Given this list of marker genes SLC25A28, WDR75, ATP10D, BEND5, TMA7, TBXT, N6AMT1, PLA2G12B, NCF2, ACTN1, DYDC2, SEZ6L2, DPF3, MRPS31, MAP1A, SLURP1, CYP2E1, NLRP12, SEMA6C, TTN (NCBI Gene Id 7847), GRB2, PPDPF, CDH10, FKTN, EGF, R3HDM2, PRKAG3, BSN, FPR2, AQP2 (NCBI Gene Id 359), IBSP, SYNPO2L, TXNDC5 (NCBI Gene Id 81567), SAGE1, PCDHGB6, ZNF462, TMEM45A, STX1B, RBM23, SPRTN (NCBI Gene Id 83932), NECTIN2, SYT4, WNT4, CNBD2, MYH14, LILRA1, PERP, CLDN14, CAPNS2, SLCO1A2, SCAPER, PGLYRP4, RGS16, NDUFA2, POF1B, GALNT15, TRAPPC6A, BLOC1S6, SUSD4, BCAS4, INPP1, REM2, DHRS3, PLXNA1, DRC7, BAAT, P2RX7, RASL12, PGS1, SNX10, KLRG1, SPP2, CDKN2B, MAPK9, IL1A, EIF3H, CRYGA, PER1, KLK11, TLX1, FETUB, XKR4, ZDBF2, HIC2, ZNF214, GTF3C4, SEMG1, DNAJC10, DMWD, TBC1D8B, UBE2C, KIAA0319, RAB27A, CDO1, NOX4, GPC4, EPS8L3, STAR, NDC80, MYO3A, TSPAN8, DNAJC28, TGM7, PABPC3, OR51E2, DSG1, HOOK1, DGKI, EIF4EBP1, WNT10B, PTPRR, TMEM200A, MUCL1 (mucin like 1), DOP1B, CREB3L1, NRXN1 (NCBI Gene Id 9378), EFCC1, RANBP3, H4C3, ZNF211, RAD21, PELI2, PRDM10, SRXN1, C8orf34, BEST3, LUM, AVIL (advillin), FOXF2, TYMP, CAPZA2, TGM3, TMED5, TXNIP, SPINK1, GABRA6, KCNV1, C22orf31, WDR46, FSTL4, CCHCR1, ROBO4, KCNB1, SHISA3, PEX11B, ZBTB25, UBE2E1, ANO10, SH3RF1, MYT1L, CCS (NCBI Gene Id 9973), RBM15, MYO15B, RIPPLY1, MXRA8, SERPINE1, MAPRE1, GIMAP5, KCNH3, GPR35, ZNF195, STK25, ANO3 (anoctamin 3), SPDEF, ST6GALNAC1, MYO16, GPR182, FAM135B, KIF3B, NXPE4, FOXJ1, HCRTR2, RGS8, LINC00839, URB1-AS1, PFAS, ASB12, TOX2, TEX14, CPA6, MAPK15, TSHB, HTRA2, VWF, TGM4, GLT8D2, ADAMTS7, THAP10, DDIT4, AKAP4, PCNP, TTC22 (NCBI Gene Id 55001), KLHL32, FAM234B, ZNF408, CYP39A1, DGCR5, SIAH1, CASR, PURG, BSCL2, GSN, HTR2B, FXYD2, TRPA1, ARSB, HMGA1, CFAP61 (NCBI Gene Id 26074), ADAT3, CPNE1, STK38L, SYNGAP1, ESPL1, ANKRD27, SERGEF, ADARB2 (adenosine deaminase RNA specific B2 (inactive)), SLC22A2, THSD7A, RTTN, VAMP8, CELA2A, P2RX3 (NCBI Gene Id 5024), KCNS2, HCG4 (HLA complex group 4), ADAMTS12, PAX2, ITLN2, BORCS8-MEF2B, PLXDC2, XPNPEP2, CPA1, GRIK2 (NCBI Gene Id 2898), EMSY, SH3TC1, NFATC4, SLC22A8, BPESC1, FBXL5, MCOLN3, MEGF11, UST, OSTC, SKAP2, SRP54, EYA1, SLC66A1LP, TMEM40 (transmembrane protein 40), ADAMTSL1, BMPR1B, NLRX1, CECR2, FBXO5, TAF4B, VPS45, ZNF79, GPC5, TLL2, C4orf17, LRRC37A, SIPA1L2, MPP4, EGR1, NTRK2, IL33, COBL, DENND3 (DENN domain containing 3), STYXL2, CACNG4, LRSAM1, RFX7, DYNC2I1, SLC39A7, TERT, GTF3C1, DMXL2, SANBR, CD72, TDRD7, NOTCH1, ANKZF1, RBM42, H2AC8, DNMT3B, RIPK4, ZNF365, HPCAL1, CNDP1, PPAT, PCDHB15, P2RY6, INMT, BTC, PBK, FCMR, TENT5B, TBX5, TIRAP, IFTAP (NCBI Gene Id 119710), KLK4, HOXB8, DPM3, CDX1, TLX2, SLC52A1, RGS14, ZNF175, OR2I1P, TOX4, TPK1, BBOX1, NUSAP1, GRP, TINCR, TAFA5, SAMHD1, ADORA1, LINC01549, COL20A1, ACE2, STRA6, TP53 (tumor protein p53), DDX39B, SERPINB5, CRB1, TMEM106C, PPP1R13B, GALNT13, ATP2B3, GYPB, CCDC65, ELAPOR1 (NCBI Gene Id 57535), ANKRD26, FAM199X, EPB41L4A, GNGT2, ZNF343, UPB1, PDE5A, SPATA31A7, ALKBH3, CACNB4, ICMT, TULP1, CIRBP, AHSG, CELSR3, HMBS, FLNC, HRAS, TCTN1, SGSH, DIS3, EDN2, LY6G6C (NCBI Gene Id 80740), MRGBP, SNURF, FMO4, ITIH5, ZCCHC4, RAB7B, METTL16, COL4A4, DLX3, PLPPR4, GRB14, NTRK3, KCNJ4, SLC35A5, PRKACB, SPZ1, NAT8, HSPB2, SAYSD1, RBM17, AKT1, NALCN, TBL3, ADAMTS5, VAMP5, NCF1C, NPVF, ADAMTS10, AJAP1, TMC5, GRIP2, KCNA4, RETREG2, ADAM6, FDX2, CHL1, DLGAP2, SLITRK5 (NCBI Gene Id 26050), TLR7, MCF2L, SRPK3, GIT2, OAS3, STK32B, OPHN1, NFATC2IP, MYL2, PSD2, MYCN, RHO, ERO1B, PLCD1, STC2, PHYHIP, CHFR, SAG, PCA3, DNAJC30, PLA2R1, CSMD3, RPS2, DOCK1, ZNF333, PSG6, LRRC8D, MRPL50, POPDC2, DDA1, CPED1, FMNL1, H1-2, ETAA1, TXNDC12, TNNT1, IRF4, TOMM22, BCAS1, SOHLH2, KRT10, EPHA7, PIMREG, CA4, MCPH1, DSCAM, ARHGAP45, RAB3C, ZNF777, OTOF, SFTPD, TMEM30A, POLR3B, TOP6BL, CTPS2, TMCC3, MED15, KCNMB3, FEZ2, BPIFA1, CABP5, ADPRHL1, KCNJ11, HIF3A, PHKG1, EPCIP, REG1B, ACYP2, AK1, GPN2, DSG2, NRP1, ICOS, RHOT1, TDRKH, RP2, IFFO1, CDC14A, TCIM, SPO11, RAD51AP1, VIL1, SYN1, HDAC9, TTI1, RBMS1, IFT140, BORCS6, SEMA6B, CELA3A, BTBD8, ENTREP1, CD5L, NPC1L1, ID2B, SLC6A16, ARMCX5, SOX1, IL17B, PPFIA2 (NCBI Gene Id 8499), INVS, LAMTOR5, SLC7A9, SMPD2, TMEM231, OTX2, ART3, USP6, VWA1, KLHL25, SCGB3A2, NXPH4, GCM2, AKR7A3, POLE2, ARHGEF25, HAS2, PGAP3, ORC6, GPRC5C, MYBPH, ACBD6, SLC2A9, FASTKD1, KLHL3, PRSS3, HOXB13, UPF3B, TOR2A, APOBEC1, BCAP29, FAHD1, CD99L2, SLC7A10, PRR5L, C2CD3, ZNF649, STXBP1, UMOD, HCRTR1, PSCA, MS4A5, MYO15A, PRRG3, CCL26, SLC26A3, CLEC3A, EEF1G, FAM83D, DDN, NXT2, ERMN, ASAP3 (ArfGAP with SH3 domain, ankyrin repeat and PH domain 3), STX11, KMT5C, EMP2, FGF5, SLC15A2, DAO, DNAJC22, S1PR5, PALLD, SPACA9, GABRA2, PLAAT5 (phospholipase A and acyltransferase 5), ZNF821, BICD1, SNX8, NOS2, MKI67, P2RY1, BHMT, here is a description of the gene set: species: Homo sapiens Genes in the cancer module 163. Human Gene Set: MODULE_163